The following is a description of a gene set: Gene expression in different thymic stromal cells and subsets thereof was analyzed in 6-12 week old wild type (C57BL/6) and Aire knock-out (mixed background) mice. Thymic stromal cells were purified by sequential enzymatic digestion (collagenase, collagenase/dispase and trypsin) followed by gradient centrifugation and FACS sorting. Sort criteria were as follows: dendritic cells (CD11c+, F4/80 -), macrophages (F4/80+, CD11c-), cTECs (CD45–/lo, CDR1/Ly51+, Ep-CAM+) and mTECs (CD45–/lo, CDR1/Ly51–, Ep-CAM+). mTECs of wild-type and Aire knock-out mice were further subdivided according to CD80 expression levels. For microarray analysis total RNA from thymic stromal cell samples of two independent experiments was pre-amplified and biotinylated by two rounds of cDNA synthesis and in vitro transcription. Fluorescence readings were evaluated by using Microarray Suite 5.0 software. Human Gene Set: GSE2585_CD80_HIGH_VS_LOW_AIRE_KO_MTEC_DN Genes down-regulated in medullary thymic epithelial cells (mTEC) with AIRE knockout: CD80 high versus low. species: Homo sapiens from publication Derbinski J, Gäbler J, Brors B, Tierling S, Jonnakuty S, Hergenhahn M, Peltonen L, Walter J, Kyewski B (PMID 15983066), and this is the list of marker genes: TRIM45, FRS3, SERPINB7, OPTC, BRCA1, SOX8 (SRY-box transcription factor 8), SEMA6D (NCBI Gene Id 80031), TMEM232, DNAH17, SNAI3, TNFSF4, SPRN, LRAT, KCNE5 (potassium voltage-gated channel subfamily E regulatory subunit 5), TBC1D17, LPL, CHP2, ANXA13, CALML4, BSND, ADGRA3, AJAP1, RECQL4, E2F2, SMKR1, SH3GL2, ALAS1, C2orf80, NMNAT2, HSD3B2, FABP4 (fatty acid binding protein 4), WSB2, PGGT1B, CCDC51, CALCB, SLC25A31, SLC36A3, ENTHD1, PRSS53, SLC35E3, FBP1, C14orf93, TOP2A, CAMK1, NEMP1, CREB3L2, SNED1, SYTL4, ITGA1, TKFC, CAMK2D, TTC36, IMPA2, SMTN, DNAI3, TONSL, SLC40A1, PLA2G4F, C8orf74, SYT9, OR4E2, CES3, COL14A1 (NCBI Gene Id 7373), PRSS22, GPC1, TOMM34, SLC6A4, SPON1, CMYA5, CDH2, ARAP3, AK8, SEPTIN11, SPAG7, FLNA, ALX1, GNG11, DAAM1, ARRDC5, MERTK (MER proto-oncogene, tyrosine kinase), IGSF9, EPS15L1, PDGFRL, SNX24, MMP17, PSMA8, TIMELESS, PRRT4, TERF2, TTC29, KRT39, VWF, LMAN2, PARS2, MAST3, TBCEL, FAM47E, NEK6, NPHS2, RAD51, UBTFL1, CDK14, TPX2, DNAAF1, SLCO6A1, PPP1R17, PREP, KIF12, NOSTRIN, C1QC, CABP4, ACCSL, CLXN, GRIK4, RSPO4, BTBD9, SCN4B, SLC8A1, KLHDC1, BHMT, TK1, NUP42, FAM151A, PI4KB, ZNF704, RTF1, GARIN4, NCAPH, LYRM7, ECT2, LEFTY2, CEP295, EXO1, HTRA4, IL7, LCN9, HOATZ, IQCF5, FAM149A, TRPM8, CP, ARHGAP33, BUB1, MAST4, KLHL23, SLC22A23, ACIN1, VCAM1, PLEKHJ1 (pleckstrin homology domain containing J1), NEK2, SCG2, NRAS, CLSPN, F11R, CORO7, ALOXE3, CLEC6A, GLB1L3, FUT4, SLC22A3, NRF1, AMDHD2, MYBL2, ZRANB3, TNR, TMEM79, SCARB2, GPRC5B, AAR2, ASPN, SFRP4, TAB1, GASK1B, ZMIZ1, CNIH3 (NCBI Gene Id 149111), PAH, AURKA, CENPH, ARHGEF15, PTGER3, ZNF148, MPDZ, APBA1, C12orf50, SPAG5, LRRTM4, ALS2, WSCD2, BMERB1, ARSG, SLC35G6, TSPAN1, PBK, GK, TBATA (NCBI Gene Id 219793), ALKBH8, HMOX1, GUCA1A, WDR5B